The following is a description of a gene set: Genes down-regulated in PANC-1-S4KD cells (pancreatic cancer; SMAD4 knocked down by RNAi) after stimulation by TGF1B for 2 h. Human Gene Set: JAZAG_TGFB1_SIGNALING_VIA_SMAD4_DN from publication Jazag A, Ijichi H, Kanai F, Imamura T, Guleng B, Ohta M, Imamura J, Tanaka Y, Tateishi K, Ikenoue T, Kawakami T, Arakawa Y, Miyagishi M, Taira K, Kawabe T, Omata M (PMID 15592526) species: Homo sapiens The transforming growth factor-beta (TGF-beta)-Smad signaling pathway inhibits the growth of human epithelial cells and plays a role in tumor suppression. The Smad4 gene is mutated or deleted in 50% of pancreatic cancers. In this study, we succeeded in establishing Smad4 knockdown (S4KD) pancreatic cancer cell lines using the stable RNA interference (RNAi) method. Smad4 protein expression was reduced dramatically and TGF-beta-Smad signaling was markedly inhibited in the S4KD cell lines. The S4KD and control cells were stimulated with TGF-beta and analysed using a cDNA microarray that contained genes, in order to screen for target molecules downstream of TGF-beta. The microarray analysis revealed that 187 S4KD genes and genes in the control cells were regulated immediately upon TGF-beta stimulation. Quantitative RT-PCR analysis on several of these genes produced results that corroborated the outcome of the microarray analysis. Most of the genes in the S4KD and control cells identified by the array differed, which suggests signaling pathways that differ according to Smad4 status. Of the identified genes, 246 have not been reported previously as genes that lie downstream of TGF-beta. Genes that are involved in cell proliferation, adhesion, and motility were found to be regulated differentially with respect to S4KD and control cells. Cell migration induced by TGF-beta was inhibited in the S4KD cells, which might be associated with a different regulation of integrin beta7. The knock down of a specific gene using stable RNAi appears to be a promising tool for analysing endogenous gene function., and this is the list of marker genes: PAK3, UNC119, SPI1, FLT3LG, GALR1, SYNGR2, BMP2, RASSF1, PKLR, HSPA4, TNFRSF10A, GUCY2F, PTK7, CDK18, VIL1 (NCBI Gene Id 7429), PNOC, AIM2, SNX10, JAG2, CNOT9, NID2, LCP2, SF1, S100A1, PDGFRB, VAPB, CYB5A, C5, MST1, CD1A, MAPK7, PTCH1, ST6GALNAC2, KCNMB1, ITGB7, FBXW10B, RBMX2, TUBA1B, CDK17, ITGA6, SLC22A6, RPL13A, CLEC11A, RBP4, LTA (lymphotoxin alpha), DRD2, LIF, HRH2, SHISA5, CCL27, MFNG, NRG1, SCAMP3 (NCBI Gene Id 255017), PRODH, NEMF, POU2F2, SH3BP2, PHLDA1, CNKSR1, BYSL, CLDN4, ABCD1, AGPAT1, ACKR1, CCNE1